Given this list of marker genes NEURL3, WFS1, GCLC, CCDC22, AXIN2, PYHIN1, FZR1, GSK3B, COP1, USP13, TRIB1, IL33, FBXW8, SMURF1, SGTA, EGF, BAG6, KCNE2, TRAF7, PSMC2, PRKN, DDA1, TMTC3, MAPK9, TRIM67, TRIB3, CDC20B, PTEN, DISC1, HSPBP1, PTK2, CEBPA (CCAAT enhancer binding protein alpha), BBS7, MTOR, NOP53, GBA1, DDRGK1, GABARAP, AGTPBP1 (ATP/GTP binding carboxypeptidase 1), AKT1, PSMC6, LAPTM5, ZYG11B, SH3RF3, TGFB1I1, TMX1, NUPR1, NFE2L2, MDM2, IKBKG, RNFT1, CHFR, HECTD1 (HECT domain E3 ubiquitin protein ligase 1), TAF1, UFL1, AXIN1, STUB1, HAMP, UBQLN1 (ubiquilin 1), CLU, PABIR1, DNAJB2 (NCBI Gene Id 3300), PSMC1, CAV1, PLK1, SOCS5, RNF180, PSMC5, RNF139, PSEN1, HERPUD1, PRICKLE1, RAD23A, CSNK1E, AGBL4, USP5, NUB1, PSMC3, HSPA1A, CDK5RAP3, PSMC4, PSMD10 (proteasome 26S subunit, non-ATPase 10), CAV3, PAQR3, DET1, SOCS4, SIRT2, DAB2, ELOB, KEAP1, CBFA2T3, SH3RF1, OSBPL7, RFPL1, FBXO22, SIRT1, BCAP31, TMEM259, ZFAND2A, RCHY1, FBXW7, ZER1, SIRT6, ATXN3, RBX1, CSNK1D, RACK1, ECSCR, PIAS1, SUMO1, KLHL40, CTSC, TF, RNF185, GSK3A, FMR1, HSPA1B, XBP1, PTK2B, LRRK2, BAG2, DVL1, SUMO2, CDC20, DAB2IP, AURKA, NKD2, TREM2, TRIB2, CSNK1A1, L3MBTL3, ATXN3L, SH3RF2, RNFT2, UBQLN2, VCP, ATP5IF1, PLK3, SMAD7, here is a description of the gene set: species: Homo sapiens Any process that activates or increases the frequency, rate or extent of proteolysis involved in protein catabolic process. Human Gene Set: GOBP_POSITIVE_REGULATION_OF_PROTEOLYSIS_INVOLVED_IN_PROTEIN_CATABOLIC_PROCESS